Given this list of marker genes RPL10A, UBE2E3, RPS5 (ribosomal protein S5), ITM2B, TMEM109, ATXN10, SKP1, ERGIC3, RAN, EIF5, ISLR, DDT, FBL (fibrillarin), ETHE1, PSMD8, AKR1B1, HSP90AB1, TMBIM6, SRSF3, B2M, NUPR1, SARS1, HINT1, RPL21, YWHAZ, RPL17, ATP5F1A (NCBI Gene Id 502), EIF3K, UQCR11, RPS2, SNTA1, CD74, RAP1GAP, RTN4, RPS12, RPL18A (NCBI Gene Id 6142), LITAF, EIF3F, CLDN7, TRIB1, PPT1, DNAJA1, TMEM147, HSPA8, FKBP1A, BLVRB, here is a description of the gene set: The demonstration of the PAX8-PPAR(gamma) fusion oncogene in a subset of follicular thyroid tumors provides a new and promising starting point to dissect the molecular genetic events involved in the development of this tumor form. In the present study, we compared the gene expression profiles of follicular thyroid carcinomas (FTCs) bearing a PAX8-PPAR(gamma) fusion against FTCs that lack this fusion. Using unsupervised clustering and multidimensional scaling analyses, we show that FTCs possessing a PAX8-PPAR(gamma) fusion have a highly uniform and distinct gene expression signature that clearly distinguishes them from FTCs without the fusion. The PAX8-PPAR(gamma)(+) FTCs grouped in a defined cluster, where highly ranked genes were mostly associated with signal transduction, cell growth and translation control. Notably, a large number of ribosomal protein and translation-associated genes were concurrently underexpressed in the FTCs with the fusion. Taken together, our findings further support that follicular carcinomas with a PAX8-PPAR(gamma) rearrangement constitute a distinct biological entity. The current data represent one step to elucidate the molecular pathways in the development of FTCs with the specific PAX8-PPAR(gamma) fusion. Human Gene Set: LUI_THYROID_CANCER_PAX8_PPARG_DN Top down-regulated genes distinguishing between follicular thyroid carcinoma (FTC) samples by the presence or absence of the PAX8-PPARG fusion protein. species: Homo sapiens from publication Lui WO, Foukakis T, Lidén J, Thoppe SR, Dwight T, Höög A, Zedenius J, Wallin G, Reimers M, Larsson C (PMID 15608688)